Given this list of marker genes ROBO1, SLIT2 (slit guidance ligand 2), ATF5, PHOX2B, SOX1, ARHGEF28, NDNF, C12orf57, ARX (aristaless related homeobox), CRK, SZT2, CNTN2, KIAA0319, FGF8, BTG2, EPHB3, NTRK2, EPHB2, DISC1, RAPGEF2, WNT5A (NCBI Gene Id 7474), DRD2, GABRB1, NFIB, SCN1B, UQCRQ, RAC3, SPG11, SLIT3, MAPT, PLXNA4, MYCBP2, GBA2, RAC1, PAFAH1B1, WDR47, SPTBN4, DRD1, MAP2, B4GALT5, NDEL1, FOXG1, CDH11, SEMA3E, ARHGAP35, TTC36, CHRNB2, GBX2, GLI2, AGTPBP1, PALS1, PLXNA1, LHX8, FGFR2, NHLH2, NRP1 (neuropilin 1), LEP, FBXO45, SECISBP2, BRINP1, AGBL4, PRKCA (protein kinase C alpha), FEZF2, EPHB1, SLC4A10, SLIT1, NRP2 (neuropilin 2), SCYL2, PRDM8, NIN (NCBI Gene Id 57681), CDK5, ZEB2, NR4A2, EPHA4, DCLK2, NR2E1 (NCBI Gene Id 7101), CRKL, DCC, GATA2, DRAXIN, TCTN1, KIFBP, ADARB1, B4GALT6, ATP7A, ROBO2, TSKU, ZMIZ1, PLXNA3, UBB, ASCL1, OGDH, PTEN, HPRT1, NOVA2, LHX6, NPY (neuropeptide Y), NANOS1, TAOK1, here is a description of the gene set: Human Gene Set: GOBP_CENTRAL_NERVOUS_SYSTEM_NEURON_DEVELOPMENT The process whose specific outcome is the progression of a neuron whose cell body is located in the central nervous system, from initial commitment of the cell to a neuronal fate, to the fully functional differentiated neuron. studied in species Homo sapiens